Given this list of marker genes ZNF827, DNAJC18, RUNX1, ZFP36L2, CDH19, TBPL1, C18orf63, SEPTIN10, SNCG, PCSK5, CASK, ATP5MC3, KRTAP4-9, CASP7, TAOK1, ZKSCAN5 (zinc finger with KRAB and SCAN domains 5), CTXN3, DHX15, GIT2, PFN2, CEP152, FNDC3B, DCC, DNAJC10, TCF7L2, ZBTB1, CDKL4, DLG3, CCDC126, CNOT6L, GTF2E2, MAN1A2, WDR35, RIOK2, LYST, SP4, UBE2D3, TECPR2, ADH6, MTF2, SORBS2, EDIL3, CFAP77, GTDC1, PRKAR1A, TSPAN19, RPAP2, PYURF, AJUBA, CDCA2, FKRP, EVI2B, NUMB, LILRB2, MIER3, RRAGC, GANC, HNRNPLL, MBOAT2, AHR, STAT6, GLIPR2, SYT14, KLF4, REEP1, ACTB, EAF1, CDC14A, MYLIP, PBK, CYB561D1, STPG2, GALNT3, KLF7, RNF128, ANKRD55, ZNF503, KCNN3, RABGAP1L, HERC3, PAIP1, FAM217A, PCDHGB7, FRMD4B, SNAI2, INTS6, PPP4R3A, PCDH10, SERP1, NRIP1, SLC39A8, CSRNP1 (NCBI Gene Id 64651), EN2 (engrailed homeobox 2), MYLK, SHE, C8orf33, CNKSR2, LPAR1, EPAS1, CAMTA1, CNOT7, PCDH11Y, COL5A2, RANBP3L, NR1D1, KRTAP4-8, ACOT13, DOT1L, TMEM230, PCDH11X, RSPRY1, SUMO2, CALD1, ZMPSTE24, KLF12, STRN3, FOXJ3, HOXA7, CLASP2, SKI, USP9X, LATS1, LIMA1, RBP3, TMEM135, ZNF426, HNRNPR, TAF4B, XRRA1, CDADC1, HDAC4 (histone deacetylase 4), ATXN7, NBEAL1, ATF1, FUT9, ETS1, ZNF689, LIN9, OSBPL3, MTREX, PRDM10, SLC38A2, CHP2, MEGF10, REV3L, TMEM68, TMC1, COL19A1, NECAB1, SFXN1, NOTCH2, NIPAL1, ANKRD13C, KDM4E, HPS3, TRPS1, ZNF480 (zinc finger protein 480), LY75, CNBP, PDCD4, REEP3, SMAD1 (NCBI Gene Id 4086), ZNF202, BOLL, SSBP2, IL10RA, SERPINF1, KRTAP4-11, PTPN4, OTOGL, SEMA3A, PCDHB2, NRBP2, SLC44A2, WAPL, KRTAP4-7, NPNT (NCBI Gene Id 255743, nephronectin), RNF123, RGL1, ANO6, UBE2G1, ADAMTSL3, MBNL2, ETNK1, CDKN2B, BAG4, IL15, KLB, DAZL, AQP4, CADM2, SERPINB10, USP14, SPHKAP, RNF186, CAPN14, FNIP2, TTC29, PLEKHA5, ING3, SLC26A7, here is a description of the gene set: Human Gene Set: MIR6505_5P from publication Chen Y, Wang X (PMID 31504780) species: Homo sapiens Genes predicted to be targets of miRBase v22 microRNA hsa-miR-6505-5p in miRDB v6.0 with MirTarget v4 prediction scores > 80 (high confidence targets).